The following is a description of a gene set: from publication Kääb S, Barth AS, Margerie D, Dugas M, Gebauer M, Zwermann L, Merk S, Pfeufer A, Steinmeyer K, Bleich M, Kreuzer E, Steinbeck G, Näbauer M (PMID 15103417) Human Gene Set: KAAB_FAILED_HEART_ATRIUM_DN species: Homo sapiens To obtain region- and disease-specific transcription profiles of human myocardial tissue, we explored mRNA expression from all four chambers of eight explanted failing, and five non-failing hearts using high-density oligonucleotide arrays (Affymetrix U95Av2). We performed pair-wise comparisons of gene expression in the categories (1) atria versus ventricles, (2) disease-regulated genes in atria and (3) disease-regulated genes in ventricles. In the 51 heart samples examined, genes showed divergent distribution between atria and ventricles (genes with higher expression in atria, genes with higher expression in ventricles). Two hundred and eighty-eight genes were differentially expressed in failing myocardium compared to non-failing hearts (genes regulated in atria and ventricles, 172 regulated in atria only, genes regulated in ventricles only). For disease-regulated genes, down-regulation was 4.5-times more common than up-regulation. Functional classification according to Gene Ontology identified specific biological patterns for differentially expressed genes. Eleven genes were validated by RT-PCR showing a good correlation with the microarray data. Our goal was to determine a gene expression fingerprint of the heart, accounting for region- and disease-specific aspects. Recognizing common gene expression patterns in heart failure will significantly contribute to the understanding of heart failure and may eventually lead to the development of pathway-specific therapies. Genes down-regulated in atria of failing hearts (DCM and ICM) compared to healthy controls., and this is the list of marker genes: STX4, SNU13, PARVB, PLP1, LAGE3, DDX21, TMEM147, ACTB, AMD1, LRRC32, GSTP1, NUDT3, ACP1, GSTM3, FKBP1A, FCN3, TAGLN, CD59, ACVR1B, PAPOLA, CDC16, YWHAZ, SS18, VAT1, CNN3, LAPTM4A, IFITM1, KPNA6, SLC9A6, DGUOK, CAPN7, PPP1CC, GSE1, SMPD4, LDHA, GPR137B (NCBI Gene Id 7107), PSMB1, MAD2L1BP, TM9SF1, MPP1, SDF2 (stromal cell derived factor 2), ELOC, PSMA3, LSM7, VAPB, YWHAE, ACTN1, EI24, IFITM3, ADRM1, EIF3I, RPA1, CTTN, SPARCL1, OPTN, HNRNPL, GLUD1, MLEC, HDGF (heparin binding growth factor, NCBI Gene Id 92300), RAD1, TPM2, MCM3, CNIH1, CCZ1 (NCBI Gene Id 51622), SPTSSA, ACOT13, PDCD6, ACOX2, COL15A1, SLCO3A1, NPRL2, GTF3A, FAM131A, SMARCA1, MAP2K1 (NCBI Gene Id 5604), GRB2, PAFAH1B1, RBP1, FKBP9, PIGH, LGMN (NCBI Gene Id 5641), TSC22D1, UBE3C, CLIC4, MPST (mercaptopyruvate sulfurtransferase), PLEKHB2, TXN, ABCB6, UBA3, PSMB4, ATP6V0E1, RAB9A, DXO (NCBI Gene Id 1797), WASHC2C, IGSF3, IFNGR1 (NCBI Gene Id 3459), PSMB3, SRI, PSMD9, RRAGA, PTPRB, PIR, LRRN3, RAB1A, NUTF2 (nuclear transport factor 2), PPM1A, USP2, G3BP2, COX6A1, PSMB5, ZP3, ZNF22, TGFBR3, VTI1B, GDE1 (glycerophosphodiester phosphodiesterase 1), PMP22, TNFAIP1, ITM2B, PRDX1, DAAM1, BLVRB, PGK1, RAN, UBE2I, PGM1, PODXL, ABCC9, RIT1, TMED10, SUMO1 (NCBI Gene Id 7341), TGFBR2, MYH10, CTNNA1, WARS1, ST3GAL1, SERPINA3, NME2, HINT1, SLC39A14, OSMR, STAT3, GPC4, LRBA, KHDC4, APP, NPTN, LYPLA1